Given this list of marker genes Apc, Dst, Clasp1 (NCBI Gene Id 76707), Mapre2, Tbcb, Pafah1b1, Clip1, Clip2, Mapre3, Kif2c, Numa1, Kif18a, Clip4, Ckap5, Mlph, Fbxw11, Mapre1, Clip3, Stim1, Knstrn, Clasp2, here is a description of the gene set: Mouse Gene Set: GOMF_MICROTUBULE_PLUS_END_BINDING studied in species Mus musculus Binding to the plus end of a microtubule.